Given this list of marker genes Gm16582, Nudt11, Adcyap1, Samd3, Barhl1, Lin7a, Barhl2, Tfap2d, A530083I20Rik, Gm27042, Adgrf2, Dbndd1, Gm28050 (NCBI Gene Id 102636013), Pou3f1, Grem2, A930036I15Rik, Eid2, Gm2164, Peg13, Tmem163, Zbtb8a, Nrn1, Slc17a6, here is a description of the gene set: Mouse Organogenesis Cell Atlas (MOCA) DE_gene_main_cluster.csv, fold.change>=1.5, qval<0.05, pval<0.05 from publication Cao J, Spielmann M, Qiu X, Huang X, Ibrahim DM, Hill AJ, Zhang F, Mundlos S, Christiansen L, Steemers FJ, Trapnell C, Shendure J (PMID 30787437) Mouse Gene Set: DESCARTES_ORGANOGENESIS_POSTMITOTIC_PREMATURE_NEURONS species: Mus musculus